Given this list of marker genes VAMP2, KCNE3, CASQ1, MMP9, KCNAB1, STAC, EDN1, GAL, SELENON, GPR35, HAP1, AHNAK (NCBI Gene Id 79026), CRACR2A, FGF12, ASPH, KCNE2, NIPSNAP2, EDNRA, CALM1, CBARP, CALM2 (NCBI Gene Id 805), STIM2, LRRC38, CTSS, FGF13, JPH2, CACNB3, CAMK2D, FMR1, KCNQ1, TMSB4X, GALR2, KCNRG, STAC2, CRHR1, KCNE1, LRRC26, HTT, CACNA1F, SCN1B, GNB5, ATPSCKMT, ANK3, ACTN2, LRRC55 (NCBI Gene Id 219527), STIM1, STIMATE, CALM3, HPCA, UBQLN1, GRP, CACNB4, SUMO1, LRRC52, STAC3, here is a description of the gene set: Any process that modulates the frequency, rate or extent of cation channel activity. Human Gene Set: GOBP_REGULATION_OF_CATION_CHANNEL_ACTIVITY species: Homo sapiens